Given this list of marker genes Pold4, Pola1, Pcna, Prim1, Rfc1, Pold2, Pold1, Pola2, Rfc3, here is a description of the gene set: part of: Lagging Strand Synthesis; Leading Strand Synthesis electronically inferred by orthology from the curated human pathway Reactome Pathway: Polymerase switching This event has been computationally inferred from an event that has been demonstrated in another species.<p>The inference is based on the homology mapping from PANTHER. Briefly, reactions for which all involved PhysicalEntities (in input, output and catalyst) have a mapped orthologue/paralogue (for complexes at least 75% of components must have a mapping) are inferred to the other species. studied in species Mus musculus